Given this list of marker genes Lrrc47, Fam3c, Slc39a11, Ccr1, Syne1, Atp5mc3, Plec, Spata31d1c, Zfp608, Nr1d2, Mrpl3, Gpr15lg, Col4a1 (collagen, type IV, alpha 1), Pnpla2, F13a1, Znrf2, St8sia2, Gfral, Mc1r, Atg14, 2310022A10Rik, Hus1, Pdlim5, Irx2, Tceal5, Cd274, Prdx6 (peroxiredoxin 6), Mogs, Scfd2, Gde1, Osgin2, Jade3, C2cd5, Ablim2, Klf13, Lrrc8d, Afdn, Tanc2, Sp8, Cadm1 (NCBI Gene Id 80622), here is a description of the gene set: Genes predicted to be targets of miRBase v22 microRNA mmu_miR_667_3p in miRDB v6.0 with MirTarget v4 prediction scores > 80 (high confidence targets). from publication Chen Y, Wang X (PMID 31504780) Mouse Gene Set: MIR_667_3P species: Mus musculus